Given this list of marker genes mt-Rnr2, Gm15564, Gm10222, mt-Tv, mt-Tp, here is a description of the gene set: from publication Yevshin I, Sharipov R, Kolmykov S, Kondrakhin Y, Kolpakov F (PMID 30445619) Mouse Gene Set: HMCES_TARGET_GENES Genes containing one or more binding sites for (Hmces) in their promoter regions (TSS -1000,+100 bp) as identified by GTRD version 20.06 ChIP-seq harmonization. studied in species Mus musculus